Given this list of marker genes Acot8, Babam1, Gtf2a2, Bad, Zfp414, Cops5, Pfdn6, Ppic, Clic1, Atp5po, Gdf3, Naa10, Tmem250, Il11ra1, Lyl1, Selp, Frat1, 1110038F14Rik, Lmo2, Esam, Cyb5a, Ppib, Ntmt1, Brix1, Serbp1, Tecr, Orai1, Tmem176a, Shisa5, Stk16, Psmb6, Sdsl (serine dehydratase-like), Atp6v0c, Dcps, Mpc1, Tmem14c, Slc25a4, Ubb-ps, Rpl5, Pmf1, Trim47, Calm1, Rbfa, Aldh1a1, Yif1b, Thoc3, Bcl2l12, Brk1, Tagln2, Atp5mc2, Znhit1, Psma2, Alad, Gar1 (GAR1 ribonucleoprotein), Eno1b, Ddah2, Scamp3, Ap2s1, Cyba, Ubl7, Itm2c, Vps72, Psmd14, Dhrs4 (NCBI Gene Id 28200), Sec13, Bud23 (NCBI Gene Id 66138), Fbxo6, Lgals9 (NCBI Gene Id 16859), Manf, Gng11, Twf1, Ppif, Akt1s1, Srm, Tmem208, Rpl4, Apbb1ip, Mif4gd, Ppp4c, Pgls, Sumo1, Rdh13, Dctn3, Npm3, Tmem242, Bccip, H2-Aa, Map2k2, Aarsd1, Prkag1, Emd, Ppp1r35, Mrpl28, Mrps26, Kdm6b, Ostf1, Fth1, Dnajc9, Zg16, Ifitm2, Rbm38, Psme2, Npc2, Sdf2l1, Rpl13, Spcs2, Anp32e, Ptma, Tmem50a, Trp53, Ccnd2, Dtd2, Rbm25, Exosc8, Ciao2a, Ubald1, Chchd2, Nr2c2ap, Sbds, Lyar, Psmc2, Fdps, Spn, Rfc2, Psmd7, Tmem219, Hpf1, Tsc22d1, Tsfm, Drap1, Psmg1, Psmd11, Atp5pb, Eif3g, Csf2ra, Sac3d1, Capzb, Trir, Bub3, Ube2l6, Fbl, Smco4, Cdc123, Gng10, Mrpl16, Atg101, Tsn, Selenow, Tspo, Scand1, Ssu72, Nme1, Vps29, Glipr1, Vti1b (NCBI Gene Id 53612), Pdrg1, Gstm1, H2-DMb1, Ppp1r15a, Acd, Gabarapl1, Dohh, Slc25a5, Dnajc8, H2-T23, Mydgf, Rnf181, Hmg20b, Zmat5, Ctsg, Eri3, Cuta, Jund, Ostc, Gpx4, Macrod1, Ubxn1, Maz, Fyb1, Klf6, Eif3k, Cd74, Atp5mc3, Parl, Zfpl1 (zinc finger like protein 1), Wdr74, Ppie, Serpina3g, Dusp1 (dual specificity phosphatase 1), Rabepk, Rab38, Swi5, Exosc7, Spint2, Ptprcap, Arpc4, Anxa5, Peg12 (NCBI Gene Id 27412), Arl6ip5, Kdelr1, Cyc1, Krt18, Nfkbib, Mlf2, Ngdn, Ahsa1, Wdr83os, BC005624, Psme1, Batf, Grina, Bcl7c, Aldoa, Spag7, Arpc1b, Polr3gl, Arpc5l, Psmd13, Idh3g, Ier3, Gstm5, Nudt9, Rrp15, Uqcrc1, Calm2 (NCBI Gene Id 75700), Rab4b, Ccdc85b, Ruvbl2, Arhgdia, Ssr2 (NCBI Gene Id 99800), Emg1, Tspan4, Ndufs7, Egfl7, Tmco1, Hsd3b7, Dnajb1, Urod, Hsd17b10, Ino80b, Tipin, Vcf1, Comt, Gnb1, Sdhc, Mrps10, Syf2, Ech1, Chchd6, Tmed1, Khk, Atp6v1d, Jun, Ctsz (NCBI Gene Id 99199), Ier2, Etfb, Snrpa, Pdlim7, Nudc, Yju2, S100a1, Oard1, Creld2, Mt1, Bsg, 1110004F10Rik, Junb (jun B proto-oncogene), Tgm2, Coq9, Psmc1, Chchd10, Apoe, Sf3b4, Ly6a, Cavin1, Nrgn, Phb2, Ddhd2, Esd, Nfkbia (nuclear factor of kappa light polypeptide gene enhancer in B cells inhibitor, alpha), Tm2d3, Spc24, Cst3, Syngr2, Psmc3, Bcap31, Tamm41, Cdkn2d (cyclin dependent kinase inhibitor 2D), Snrpc, Phb1, Sat1, Pin1, Abhd11, Rabac1, Lyz2, Map1lc3a, Selenos, Cfl1 (NCBI Gene Id 12631), Atp5f1c, Rbm3, Ddx39a, Rack1, Ndufa12 (NADH:ubiquinone oxidoreductase subunit A12), Fam98c, Gatd1, Tmed10 (transmembrane p24 trafficking protein 10), Wbp2, Psma7, Limd2, Egr1, Plin3, Ifi35, Vmp1, Tmem222, Nop53, Mdh2, Ap3s1, Ube2e1, Sfxn1, Nt5c3b, Mrpl12, Ift27, Cd63, Yeats4, C1qbp, Cirbp, Fos, Car1, Vamp5, Srgn, Ccdc124, Ppig, Csnk2b, H2-M3, Lmo4, Aimp1, Qtrt1 (NCBI Gene Id 70199), Bcat2, Lrrc8a, Mrpl58, H2-Ab1, Alox5ap, Atp6v0e, Ifi47, Basp1, Stmn1, Gp9, Nop16, Tomm40, Sparc, B2m, Eif3m, Emc10, Sin3b, Wdr18, Guk1, Hacd4, Ptpn1, Smim14, Pold4, Rplp0, S100a6, Aamp, Tmem9, Stxbp4, Dok1, BC031181, Cdk2ap2, Shfl, Galk1, Vkorc1, Sumo3, Tmem160 (transmembrane protein 160), Asf1b, Smim5, G6pc3, 2510002D24Rik, Rpl14, H2-K1, Bst2, Manbal, Pycr3, Cope, Mdh1, Prelid3b, Psmd4 (proteasome (prosome, macropain) 26S subunit, non-ATPase, 4), Lat, BC004004, Cotl1, Timm50, Snrpa1, Cuedc2, Sod2, Smim20, Psmb8, Pim1, Tubb4b, Pfn1 (profilin 1), H3f3b, Kmt2b, H2-D1, Ppp1ca, Map1lc3b, Hmgb3, Dnph1, E2f4, Gatd3a, Mrpl2, Serpinb1a, Cdkn1c, Psma5, Cdc37, Atp5f1d, Tmem97, Cnpy2, Mrpl22, Chmp2a, Uck2, Creg1, Tmem11, Rbm42, Tex261, Ypel3 (yippee like 3), F11r, Mpc2, Cox5a, Tmbim4, Mrps18a, Nubp1, Rab5if, Hscb, Mpdu1, Fkbp3, N6amt1, Timm44, Mrps11, Capg, Hmbs, Eif5a, Tmed3, Tmem234, Txn2, Dnajc3, Psmd8, Gfi1b, Spi1, Srsf5, Prdx6, Fosb, Elovl1, Csn3, Bnip3l, Hmgn2, Vamp8, Ube2v1, Cd79b, Eef1d, Clpp, Tmed9, Thoc7, Polr2g, Akr1a1, Sarnp, Prr13, Ftl1, Rrp1 (ribosomal RNA processing 1), Unc119, Sec11a, Copz1 (NCBI Gene Id 80513), Pold2, Ndufs3, Rnf125, Lsm4, Lsm2, Glrx3, Ubb, Trappc4, H2ax, Pdlim1, Elof1, Nabp2, Gipc1, H2-Q6, Snrnp70, Mrto4, Faap20, Pfdn1, Lman2, Tmem176b, Isyna1, Uchl5, Tomm6, Mtch2, C1d, Mrps18b, Nudt16l1, Prelid1, Gstp1, Mmp24os1, Eif3i, Ube2m, Ece1, S1pr4, Ptp4a2, Yif1a, U2af1, Stoml2 (stomatin (Epb7.2)-like 2), Aup1, Apex1, Lamtor1, Rps3a1, Myl10, Chchd4, Skic8, Hdgf, Cbx1, Ube2l3 (ubiquitin-conjugating enzyme E2L 3), Cd9, Pgp, Nhp2 (NHP2 ribonucleoprotein), Ndufa8, Sdhd, Lrpap1, Isg20 (NCBI Gene Id 80487), Inka1, Pebp1, Grpel1, Ak2, Fxn, Dgcr6, Tuba4a, Pqbp1, Nosip, Ebna1bp2, Eif3h, Polr2e, Rnaset2b, Pkig, Mospd3, Ino80e, Mri1, Ptms, Cdc42ep3, Selenok, Psmb9, Slc25a3, Necap2 (NECAP endocytosis associated 2), Nfu1, Tmsb4x, Car2, Ldha, Mrpl17, Gadd45gip1, Tuba1c, Fkbp2, Trappc6a, Igtp, Psmb10 (proteasome (prosome, macropain) subunit, beta type 10), C1qtnf12, Gata3 (NCBI Gene Id 14462), Pdzk1ip1, Crlf2, Plekhj1, Stub1, Mvb12a, Sdf4, Spr, H2-Eb1, Zfand2b, Ybx1, Szrd1, Tmsb10, Emc4, Nfic, Nfkbiz, Hmox2, Ctsb (NCBI Gene Id 210034), Prtn3, Rps3, Exosc5, Park7, Psmb4 (NCBI Gene Id 19172), Bri3bp (NCBI Gene Id 76809), Ndn, Rps7, Icam2, Pomp, Lamtor4, Tyms, Ndufa10, Psmc5, Tmem40, Srsf9, H1f0, Ssna1, Taf9, Ndufv2, Anp32b, Abcg1, Iigp1c, Ssbp4, Npdc1, Smarcb1, Gclm, Laptm4a, Prdx5, Tle5, Rgs1, Ndufa9, Mrpl38, Eif3f, Tk1, Mtarc2, Ap1s1, Smim30, Dtymk (deoxythymidylate kinase), Rpl13a, Jtb, Ciapin1, Tbcb, Chrac1, Fkbp8, Sf3b2, Clu, Prdx1, Ppp1r11, Ormdl3, Cfdp1, Samm50, Sgf29, Naa80, Rpl3, Myct1, Arl2, Erp29, Emc7, Eno1, Nt5c3, Ctsl, Sult1a1, H2-DMa, Ppil1, Erh, Npm1, Psmc4, Plscr1, Arl6ip4, Mrps12, Pih1d1, Rbm26, Oaz1, Ranbp1, Fxyd5, Psmb2, Slc48a1, Arpc3, Rchy1, Blvrb, Rfc4, Nubp2, Ddrgk1, Htra2, Rexo2, Mrpl41, Klf13, Ssr4 (signal sequence receptor, delta), Rpsa, Atp6v0b, 2210016L21Rik, Psma3, Snrpb, Gtf3a, Eif4ebp1, Ndufs2, Eif2b4, Rpl6, Tm2d2, Xist, Psma6, Ube2k, Nudt3, Commd7, Adrm1, Zfp36, Cltb, H13, Tssc4, Ppa1, Lxn, Psmd12, Eif6, Trappc3, Mcrip1, Dtd1, here is a description of the gene set: from publication Tabula Muris Consortium (PMID 32669714) studied in species Mus musculus Mouse Gene Set: TABULA_MURIS_SENIS_MARROW_HEMATOPOIETIC_STEM_CELL_AGEING